The following is a description of a gene set: Writer's cramp Human Gene Set: HP_WRITER_S_CRAMP studied in species Homo sapiens A focal dystonia of the fingers, hand, and/or forearm that appears when the affected person attempts to do a task that requires fine motor movements such as writing or playing a musical instrument., and this is the list of marker genes: THAP1, CIZ1, KCNN2, KCTD17, TBP, PLP1, PRRT2, FTL, SGCE, CHD8, AOPEP, GCH1, COL6A3, TOR1A, DRD2, HINT1, CASR, KCNA1, TBC1D24, VPS16, GNA11